Given this list of marker genes Mef2c, Ccl12, Dlk1, Flt1, Col4a3, Tsc2, Pparg, here is a description of the gene set: Any process that stops, prevents or reduces the frequency, rate or extent of vascular endothelial cell proliferation. Mouse Gene Set: GOBP_NEGATIVE_REGULATION_OF_VASCULAR_ENDOTHELIAL_CELL_PROLIFERATION species: Mus musculus